The following is a description of a gene set: species: Mus musculus Mouse Gene Set: GOBP_POSITIVE_REGULATION_OF_NUCLEOCYTOPLASMIC_TRANSPORT Any process that activates or increases the frequency, rate or extent of the directed movement of substances between the nucleus and the cytoplasm., and this is the list of marker genes: Ptgs2, Brca1, Ran, Mdm2, Sirt6, Ipo5, Ubr5, Ep300, Emd, Tpr (NCBI Gene Id 74816), Hsp90aa1 (NCBI Gene Id 15524), Lep (leptin), Il6, Sfn, Jup, Dhx9, Riok2, Anp32b, Hsp90ab1, Rbm22, Hdac3, Wipf1, Shh, Ptpn5, Camk1, Ect2, Prkd1, Flna, Gli3, Tgfb1 (NCBI Gene Id 21803), Jak2, Zpr1, Mapk1, Ptpn22, Camk4, Gas6, Hcls1, Tardbp, Prkcq, Pik3r1, Nutf2, Nedd4, Akap5, Tek, Tnfrsf1a, Nutf2-ps1, Prkaca, Nrde2, Pik3r2, Mapk14, Mavs, Chp2, Ncbp2, Smo, Rapgef3, Gper1, Psen1, Khdrbs1, Cdk1, Prkcd, Zc3h12a, Xpo4, Trim28, Ifng, Ctdspl2, Uaca, Prpf4b, Cpsf6, Xbp1, Bag3, Ywhae (tyrosine 3-monooxygenase/tryptophan 5-monooxygenase activation protein, epsilon polypeptide), Hyal2, Dmap1, Ppm1a, Gsk3b, Cdh1, Zic1, Efcab7